The following is a description of a gene set: studied in species Homo sapiens Human Gene Set: GOCC_HEMOGLOBIN_COMPLEX An iron-containing, oxygen carrying complex. In vertebrates it is made up of two pairs of associated globin polypeptide chains, each chain carrying a noncovalently bound heme prosthetic group., and this is the list of marker genes: HBG2, CYB5R3, HBE1, HBG1, HBA1, HBA2, AHSP, HBM, HBZ, HBD, HBQ1, HBB